The following is a description of a gene set: species: Homo sapiens Human Gene Set: REACTOME_PRE_NOTCH_PROCESSING_IN_GOLGI Pre-NOTCH Processing in Golgi, and this is the list of marker genes: B4GALT1, ST3GAL6, ATP2A1, ATP2A2, TMED2, RAB6A (RAB6A, member RAS oncogene family), NOTCH1, RFNG, SEL1L, ATP2A3, ST3GAL3, NOTCH4, MFNG, NOTCH3, LFNG, NOTCH2, ST3GAL4, FURIN